Given this list of marker genes TONSL, SLC3A2, LMNA, COMMD3, CELA2B, RRP1, ABHD14A, GBX2, PCYT1B, IFI6, VSX1, XBP1, MAPK12, NMRK1, TIMP1, SAMSN1, KCNG2, SLC1A4, SLAMF7, MAGEH1, TFG, TM7SF2, PROC, TUBB2A, MIP, GJA3, ATOX1, BET1L, COMT, ZBTB32, SPAG4, MACROD1, ITFG1, MAN1A1, GBA1LP, RAB40B, MAPKAPK5-AS1, IMPDH1, GAMT, TM9SF1, NEU1, ISOC2, SIL1, BLVRB, CD27, CKAP4, PEX10, LIME1, SMPDL3B, WIPI1, EXT1, PODXL2, MANEA, FER1L4, NENF, QPCT, IGF1, BHLHE41, PCDHGA10, SDC1, QPRT, COPG1, DEXI, GLT8D1, NAGLU, ASB6, TRIB1, VKORC1, SEC24A, MGAT1, BSCL2, PGRMC2, GMPPA, RPN1, PDK1, IDUA, THEMIS2, LGALS1, FZD2, YIPF2, NT5DC2, HSPA13, TMEM214, FAH, HAX1, KDELR1, CAV1, CLIC3, RORA, DERL2, TPSD1, TRAM2, ERCC2, SEC14L1, HYOU1, RCN1, SLC25A4, FICD, CD38, MZB1, PREB, CNPY2 (canopy FGF signaling regulator 2), TIMP2, DNAJC3, OPTN, TOR3A, TBL2, ANG, TMCO1, LAMP2, ZBTB38 (zinc finger and BTB domain containing 38), RAPGEF2, CDKN1A, SRM (spermidine synthase), MBNL2, GPR25, RPS6KB2, GARS1, TP73 (tumor protein p73), ACADVL, DPAGT1, ABCB8, LMF1, GP1BB, ORMDL2, DCPS, YIPF5, CLCC1, AARS1, LY96, IGHA1, DNAJC1, TMEM208, SRGN, ST6GALNAC4, TNFRSF17, ARHGEF16, UBA5, TMEM115, CKAP2, B4GALT4, SSR3, CD14, CITED2, NFKBIL1, EHD4, FBP1 (NCBI Gene Id 2203), LRRC59, DNASE1L2, IDH2, MDK (midkine), P4HB, STT3A, SCT, MPC1, CRELD2, IGLV4-60, ANXA2P2, UAP1, CST3, ITGA6, RRAD, NME1, CFLAR, SRPRB, PCCB, SEC23B, HOMER3, TYMP, TPM4, RALGDS (ral guanine nucleotide dissociation stimulator), RRBP1 (NCBI Gene Id 6238), HSD17B8, ATF5, RUNX1, PLA2G15, COL7A1 (collagen type VII alpha 1 chain), DNASE2, PLAAT3, SLC35B1, NUCB2, SLC39A7, MAST1, RTN3, SAR1B, FNDC3B, B4GALT3, IFNAR2 (NCBI Gene Id 3455), PDXK, WNT4, PDIA4, MIR22HG, AMH, KDELR2, ARFGAP3, ITM2C, AMPD1, ERGIC2, here is a description of the gene set: studied in species Homo sapiens from publication Abbas AR, Baldwin D, Ma Y, Ouyang W, Gurney A, Martin F, Fong S, van Lookeren Campagne M, Godowski P, Williams PM, Chan AC, Clark HF (PMID 15789058) Immune cell-specific expression is one indication of the importance of a gene's role in the immune response. In order to identify such patterns, we set out to broadly profile gene expression in a variety of immune cells. Genes down-regulated in comparison of naive B cells versus plasma cells from bone marrow and blood. Human Gene Set: GSE22886_NAIVE_BCELL_VS_BM_PLASMA_CELL_DN